Given this list of marker genes ABCB11, here is a description of the gene set: part of: ABC transporter disorders The bile salt export pump ABCB11 mediates the release of bile salts from liver cells into bile. Defects in ABCB11 can cause two clinically distinct forms of cholestasis; progressive familial intrahepatic cholestasis 2 (PFIC2; MIM:601847) and benign recurrent intrahepatic cholestasis 2 (BRIC2; MIM:605479). Cholestasis is characterized by the retention of bile acids or salts. Bile acids can damage hepatocytes and bile duct cells leading to inflammation, fibrosis, cirrhosis and eventually carcinogenesis. PFIC2 patients suffer from chronic cholestasis and develop liver fibrosis, cirrhosis and end-stage liver disease before adulthood. BRIC2 patients experience intermittent episodes of cholestasis that resolve spontaneously after weeks or months. Reactome Pathway: Defective ABCB11 causes PFIC2 and BRIC2 species: Homo sapiens